Given this list of marker genes IL24, MEST, LOXL2, C1QTNF6, BPGM (NCBI Gene Id 669), SPON2, COL18A1, WNT5A, GPM6B, NOTCH3, HES4, SPATS2L, HSPA1A, PDGFRB, MMP11, PLXDC1, ID4, PAG1, TMEM204, HTRA3, TGFB3, ASPN, COL4A1, SFRP2, CHCHD10, POSTN, APCDD1, COL4A2, SPRY1, TNFRSF21, COL7A1, BST2, LAMB1, COL5A3, GGT5, PRSS23, GUCY1A1, NREP, APOE, F2R, TNFAIP6, ITGA1, CHN1, OLFM2, FMOD, SPARCL1, LAMP5, CTSC, IGFBP3, CYGB (NCBI Gene Id 124510, cytoglobin), here is a description of the gene set: from publication Gavish A, Tyler M, Greenwald AC, Hoefflin R, Simkin D, Tschernichovsky R, Galili Darnell N, Somech E, Barbolin C, Antman T, Kovarsky D, Barrett T, Gonzalez Castro LN, Halder D, Chanoch-Myers R, Laffy J, Mints M, Wider A, Tal R, Spitzer A, Hara T, Raitses-Gurevich M, Stossel C, Golan T, Tirosh A, Suvà ML, Puram SV, Tirosh I (PMID 37258682) species: Homo sapiens Genes upregulated in subsets of cells of a given type within various tumors In this study, an extensive analysis was conducted to define meta-programs (MPs) capturing intra-tumor heterogeneity across a spectrum of tumor types. The approach utilized non-negative matrix factorization (NMF) to analyze each cell type separately within individual tumor samples. This involved the analysis of malignant cells, macrophages, fibroblasts, endothelial cells, epithelial cells, T-cells, and B-cells. NMF was executed with varying parameter values (K=4, 5, 6, 7, 8, 9), thereby generating 39 programs for each cell type per sample. Each NMF program was summarized by the top genes based on NMF coefficients.\nRobust MPs were then delineated for each cell type using a set of stringent criteria, including recurrence within the same tumor, similarity to programs in other tumors, and non-redundancy within a tumor. Subsequently, these robust NMF programs were clustered (per cell type) based on Jaccard similarity, leading to the identification of MPs associated with each cell type.\nTo enhance the quality of the MPs, a refinement steps were undertaken, involving the removal of MPs suspected of reflecting low-quality data (with an overrepresentation of ribosomal proteins or mitochondrial-encoded genes), single-study inclusion, or similarity to miss-annotated cell types. Human Gene Set: GAVISH_3CA_METAPROGRAM_FIBROBLASTS_CAF_2